Given this list of marker genes PHF24, PAF1, AEN, BTF3, SLC23A2, SPICE1, INO80D, NPM1, WDR48, LTBP1, EIF5, EMC4, CD1C, IFI30, ATM, EIF1AX, IL2, CCR5, AK2 (adenylate kinase 2), LHX8, SERPINB3, HECW2, SERPINB4 (serpin family B member 4), ARHGAP28, ANTXR1, TMEM181, ADCY1, APEX1, LDLRAP1, CHURC1, RFK, PPP4R3B, THNSL1, WDR89, EXOC8, TSHZ3, GSDMA, here is a description of the gene set: from publication Chen Y, Wang X (PMID 31504780) Genes predicted to be targets of miRBase v22 microRNA hsa-miR-27a-5p in miRDB v6.0 with MirTarget v4 prediction scores > 80 (high confidence targets). Human Gene Set: MIR27A_5P studied in species Homo sapiens